The following is a description of a gene set: Transcription factor complex which interacts with E-box regulatory elements in target genes, including Period (Per1, Per2, Per3) and Cryptochrome (Cry1, Cry2), to activate their transcription during the daytime. The CRY-PER complexes inhibit CLOCK-BMAL1-driven transcription in a negative feedback loop to generate circadian rhythms. Mouse Gene Set: GOCC_CLOCK_BMAL_TRANSCRIPTION_COMPLEX species: Mus musculus, and this is the list of marker genes: Bmal2, Npas2, Bmal1, Clock, Pasd1